The following is a description of a gene set: The sliding of actin thin filaments and myosin thick filaments past each other in muscle contraction. This involves a process of interaction of myosin located on a thick filament with actin located on a thin filament. During this process ATP is split and forces are generated. Mouse Gene Set: GOBP_MUSCLE_FILAMENT_SLIDING species: Mus musculus, and this is the list of marker genes: Tpm1, Tnnt2, Dbn1, Tnnc1, Myh8, Mylk2, Tnni3, Myh6, Myl6, Myl6b, Myh7 (NCBI Gene Id 17889)